Given this list of marker genes PTCH1, SHH, GAS1, DHH, CDON, IHH, HHIP, BOC, here is a description of the gene set: Ligand-receptor interactions species: Homo sapiens Human Gene Set: REACTOME_LIGAND_RECEPTOR_INTERACTIONS